The following is a description of a gene set: from publication Hill JA, Feuerer M, Tash K, Haxhinasto S, Perez J, Melamed R, Mathis D, Benoist C (PMID 18024188) Human Gene Set: GSE7460_TCONV_VS_TREG_THYMUS_DN Genes down-regulated in comparison of TconvThy versus TregThy (see Fig. 1 in the paper for details). The transcription factor Foxp3 is usually considered the master regulator for the CD4+CD25+ studied in species Homo sapiens, and this is the list of marker genes: IGSF3, RAB8B, TENT5A, ZNF229, BLTP3A (NCBI Gene Id 54887), ACOT7, FOSL2, DGAT2, NAF1, TNFSF8, MAF, BHLHE40, AHR, ITGAE, PLSCR1, SH3BGRL2, ACTR3B, ANKRD2, MGAT5, PENK, GCH1, NKG7, OAS1, S100A10 (S100 calcium binding protein A10), NRP1, ICOS, IKZF3, PRKAG2, RSPH3, LTB4R, PLAGL1, CISH, IL2RA, CCL5, PLCB3, LIMA1, GBP4, PNP, PRKRA, RGS16, GZMB, TNFSF11, ITGB8, CEBPB, S100A6, FCGR2B, IRAK1BP1, PLA2G4F, CNDP2, NOTCH2, MED7, CD83, ODC1, MAP3K8, PECR, TNFRSF4, MYO1D, OSBPL3, FOXP3, NRP2, HSP90AA1, RGS1, MAPRE2, LYPLAL1, PHLPP1, ELK3, MYADM, MXD1, PLPP1, DUSP4, NEFH, BCL2A1, ARHGAP20 (NCBI Gene Id 57569), GMCL1, PIK3R2, CA5B, RBIS, WLS, MYO3B, RAPSN, CHSY3 (chondroitin sulfate synthase 3), MDFIC, IL2RB, TNFRSF1B, SLC22A2, CHST11, AK3, CD40, CHCHD7, ZNRF4, CASP4, TNFSF14, PUS7, EID2, HLA-B, TAF11, ARL5A, CYP4V2, RNF216, ATXN1, PRNP, KCNK1, RRAS, KIAA0319, PPP1R37, CORO2A, FGL2, DUSP5, FAM162A, USP27X, PRDM1, IL1R2, GADD45G, EBI3, SEMA6D, S100A11, PTPRS, HEMK1, MRPS24, CRIM1 (cysteine rich transmembrane BMP regulator 1), TTN, PGLYRP1, IKZF4, GPR15, MCUB, GSTO1, PSEN2, MTMR3, KLF9, NCF4, CXCR3, PIM1, NCKAP1, METTL6, PVT1, S100A4, SRGN, MEIS3, PTGER4, PCYOX1L, GABARAPL1, TTLL9, CSRP2, STX11, IL10RB, LCLAT1, MYO1E, CHCHD10, PXDC1, CTLA4 (NCBI Gene Id 3411), SOCS2, SNX3, STARD4, IFNGR1, BCL2L15, REEP3, SLC14A1, ATOSB, IKZF2, EOMES, PLAAT3, AHCYL2, PTER (NCBI Gene Id 9317), NXPE4, SNX10, TGIF1, VAV2, USP11, RLBP1, CCR6, PTPN9, KIF5C, NIBAN1, PRR13, ADAM19, CAPSL, TSPAN13, TNFRSF9, SUB1, RNF135, CRLS1, TMEM176B, PCTP (phosphatidylcholine transfer protein), PEAK1 (NCBI Gene Id 79834), ITGB1, NTN4, ARL6, CD38, IL18R1, NFXL1, CXCR6, PDZK1IP1, RNPEP, TMEM140, NTN1, MIF4GD, KLRG1, PTGER2, TTC28, LGALS3